The following is a description of a gene set: Human Gene Set: HP_LEFT_VENTRICULAR_OUTFLOW_TRACT_OBSTRUCTION Left ventricular outflow tract obstruction Left ventricular outflow tract (LVOT) obstruction can occur at the valvular, subvalvular, or supravalvular level. In general, there is an obstruction to forward flow which increases afterload, and if untreated, can result in hypertrophy, dilatation, and eventual failure of the left ventricle. species: Homo sapiens, and this is the list of marker genes: TAB2, MYH6, FHOD3, VCL (NCBI Gene Id 7414), KLHL24 (kelch like family member 24), GDF1, NR2F2, GAA